The following is a description of a gene set: studied in species Homo sapiens from publication West EE, Youngblood B, Tan WG, Jin HT, Araki K, Alexe G, Konieczny BT, Calpe S, Freeman GJ, Terhorst C, Haining WN, Ahmed R (PMID 21856186) Genes down-regulated in comparison of splenic secondary CD8 effector T cells at day 8 post-acute infection versus splenic secondary CD8 effector T cells at day 8 post-chronic infection. Human Gene Set: GSE30962_ACUTE_VS_CHRONIC_LCMV_SECONDARY_INF_CD8_TCELL_DN Understanding the response of memory CD8 T cells to persistent antigen re-stimulation and the role of CD4 T cell help is critical to the design of successful vaccines for chronic diseases. However, studies comparing the protective abilities and qualities of memory and naïve cells have been mostly performed in acute infections, and little is known about their roles during chronic infections. Herein, we show that memory cells dominate over naïve cells and are protective when present in large enough numbers to quickly reduce infection. In contrast, when infection is not rapidly reduced, memory cells are quickly lost, unlike naïve cells. This loss of memory cells is due to (i) an early block in cell proliferation, (ii) selective regulation by the inhibitory receptor 2B4, and (iii) increased reliance on CD4 T cell help. These findings have important implications towards the design of T cell vaccines against chronic infections and tumors., and this is the list of marker genes: SPATS2, RSAD2, CEP83-DT, PMVK, PDCD1, DUT, SPRED1, MICU3, LAMP2, CEP43, AMIGO1, DHFR, GFI1, CD109, PHACTR2, SHCBP1, IFI27L2, EPCAM, NPNT, IL21, BRCA1, RUVBL1, COX5A, FARP1, INO80C, INPP4B, MIPEP, NUP93, DELE1, SPC25, CASP3, PPIL1, GNPTAB, PSMB7, CDKN3, LPGAT1, DTL, NDFIP2, NDUFAF7, CD244, AIFM1, CCDC28B, TWSG1, LITAF, GINS1, TNFRSF9, TFRC, IPCEF1, RAD51AP1, IFT80, MCM10, GAR1, PFKFB1 (6-phosphofructo-2-kinase/fructose-2,6-biphosphatase 1), RGS16, EHD4, ADGRG1, LSM6, IL1R2, SEMA7A, SEC63, CEP57, CEP128, RNF128, FILIP1, ZAP70, PRC1, ESCO2, NCF1, CYTH3, TIPIN, C12orf75, HOOK1, XPNPEP1, LAG3, HSD17B12, SEMA4C, JDP2, EGR2, PCGF5, EGR1, ISG20, LDHA, AKR1B15, PIP4K2A, MED7, BCAP29, HELLS, POGLUT3, TK1 (thymidine kinase 1), SYNPO, MCM8, RCN1 (NCBI Gene Id 5954), IQGAP3, ZWILCH, BCL2A1, ACOXL, TPX2, TSR1, STMN1, NAPSA (NCBI Gene Id 9476), SERPINE2, GPD2, TACC2, HPF1, SKAP2, ST14, SMC2, PLXND1, SRFBP1, RAD51, GPR65, NMRAL1, DSCC1, LSM2 (LSM2 homolog, U6 small nuclear RNA and mRNA degradation associated), CORO2A, XCL1, TYMS, SERPINB9, BTBD19, ARHGAP11A, CENPE, CIP2A, BTF3L4, FAXC, HRH4, RRM1, CPT1A, SNX9, KIF20B, STT3B, CD81, KIF22, PLK4, RTP4, SLC35G1, ITIH5, BIRC5, C9orf152, GCNT1, TACC3, DNAJB13, IFI30, DUSP6, CEP19, NDRG1, ICA1, FAM3C, SRGAP3, TOP2A, E2F1, CHST2, SMYD2, EZH2 (NCBI Gene Id 392834), SNRNP35, GBP6, FRMD4B, PBK, SC5D, NR4A2, IFNGR1, CD160, HHEX, DDX1, EPDR1, RRM2, CENPH, IRF8, HMGB3, BARD1, SMARCA5, CDC14A, KNL1, CLSPN, PPA1, SMCHD1, GLRX, TMCC3, NAMPT, CLPB, KALRN, GLIPR1, PAQR4, STARD4, PTPN12, DYNLL2, OXSR1, ZNF367, TEX9, ALYREF, UBASH3B, PERP, CKAP2L, GCSH, TMEM38B, TMBIM1, NASP, HMBS, PITPNM2, FAM20A, PTGER2